Given this list of marker genes RNF152, LRCH2, MAP2K1, RNF139 (NCBI Gene Id 11236), RYK, TBX15, EIF5, SOX6, PGAP1, IRS1, ZFP36L1, PAK1, ARSJ, CTDSP1, TBL1X, AKAP1, TAC1, FRMPD4, STARD7, SLC1A1, CELF6, SLC25A25, HOXA5, PMEPA1, RAB8B, PLOD2, FLOT2, AZIN1, LRIG1, RIMS4, MAB21L2, VAT1, PCGF5, SP7, MORF4L1, PLAGL1, DENND2C (DENN domain containing 2C), BRINP2, SLC18A3, KRAS (NCBI Gene Id 3845), LDB1, SORT1, ANKRD27, KLF3, ST7, RGS2, SDC2 (NCBI Gene Id 6383), NACC1, CYGB, DHCR24, ZNF704, ZCCHC3, CACNB4, GGA2, MTMR12, FOXQ1, MORF4L2, CPSF7, RAB35, ATG16L1, PRRX1, SCYL3, LUZP1, TMEM163, RUFY1, SLC10A3, EPB41L3, MITF, HDAC9, TRIM46, CBX6, CNNM3, LAMC1, PRKCE, CACNA1C, GRID1, SEC62, SLC10A7, PLPBP, CACNB1, TSC22D3, ABAT, CAV1, NAA50, BICRAL, PLPPR4, RHPN2, HSPA2, SSC4D, FOXO1, GPRC5B, NTN4, TRIB3, CDK5R2, RAP1GAP2, ABCA1, HOOK3, SLC39A1, DDAH1, POLR2D, PLCB4, NEXMIF, ACE, ERC2, JAZF1, PPP3R1, SLF2, MAGI1, CDC42BPB, PTP4A1, SPAST (NCBI Gene Id 6683), NR4A3, CACNA2D2, FOXF2, CYRIB, BTBD3, CD164, WIPI2, GPM6A, SLC6A9, PPP1R12C, TM9SF4, KCTD16, DPY19L3, KMT2A, RNF183, PLSCR3, ZDHHC17, NIPBL, BCR (NCBI Gene Id 729775), EXT1, NRXN1, RPS6KB2, SH3KBP1, TUT4, UCK2, TACC1, COL13A1, SOX5, FAM81A, SLC39A10, BSDC1, ACVR2A, VAT1L, USF3, INSIG2, NABP1, TMX1, ADCY6, SLC9A2, FOXK2, TPM1, TGFBR1, OR51E2, ZFHX4, MTOR, GALNT2, SEMA6A, TTYH3, ZHX2, JMJD1C, CREB3L2, CEP192, RAB23, YIPF4, EVI5L, TLL1, MSN, BRWD1, SLC12A5, ITPR2, PRRT3, RAPGEF4, SH3BP5, FAF2, SHC1, CRKL, ALK, LCP1, INA, KPNB1, CABP1, GRHL2, SLC1A2, GID4, KLK15, CELF2, STK35, SLC25A1, PHF20L1, ST3GAL3, CASP2, TSKU, TBX1, DLGAP2, XKR4, GRM1, MAP2K3, EPHA3, NPTX2, LCOR, CAMTA1, DERL2, LAMP2 (NCBI Gene Id 3920), CHST10, PTGER3, GAN, ZFC3H1, COA4, ZFAND5, SLC38A4, AP3S1, GPC3, TMEM198, CHST1, RIC8B, LDB2, MAP3K3, PTPN9, ARHGEF12, ADGRB3, PAPPA, SNX16, ARID5B, MTSS1, LDLRAD4, ABCD1 (ATP binding cassette subfamily D member 1), FBXW11 (F-box and WD repeat domain containing 11), HBEGF, FARP1, EZR, CEP170, NHLH2, PPP4R3A, NOVA1, VAMP8, NLGN2, ABCA2, SH3PXD2B, PPP1R9B, TNS3, EBF3, DLAT, SLC25A42, DOCK1, SLC22A5, SLC35A1, UBE2G1, ATXN1, B4GALNT1, AIFM3, CNN3, COBL, COL9A1, ADGRA2, ZHX1, ZIC2, IGF2BP1, SYPL2, CSF1 (NCBI Gene Id 1435), INPP5A, XIAP, ZBTB41, PPM1F, EDEM1 (ER degradation enhancing alpha-mannosidase like protein 1), MFN1 (NCBI Gene Id 55669), E2F5, KLHL7, REV1, ERLIN1, MECP2, OXSR1, FOXO4, TMBIM6, OGT, SLC7A8, EPB41L4B, GPM6B, OVOL1, BRPF3, TBC1D22B, NANOS1, SPEN, CPEB4, MYRIP, MTMR3 (myotubularin related protein 3), SEPTIN11, CELSR2, RICTOR, CTNND1, ATG9A, FYN, PDLIM7, ARPP19, JPT2, RALGPS1, CEP170B, SLC16A7, PRKAR1A, ARHGAP24, CSRNP1, BACH2, CELSR1, EIF4EBP2, here is a description of the gene set: species: Homo sapiens Human Gene Set: GTGCCAA_MIR96 Genes having at least one occurence of the motif GTGCCAA in their 3' untranslated region. The motif represents putative target (that is, seed match) of human mature miRNA hsa-miR-96 (v7.1 miRBase).